Given this list of marker genes APOBR, OGFRL1, NEXN, DYSF, ATP6V1A, DUSP3, FCGR2C, ADA2, MAN2B1, TM9SF2, ASAH1, ADAMTSL4, RHOQ, FMNL2, GSTP1, IGSF6, SCPEP1 (NCBI Gene Id 59342), RAB24, B3GNT5, BMP2K, SPARC, CEBPA, TDRD9, TMEM121B, RNF13, RP2, STXBP2, KIAA0513, PDLIM1, FPR2, ABHD5, MYD88, IGKV1D-13, NCEH1, TET3, ZFHX3, PLXNC1, CD9, MLC1, PTAFR, SMIM14, LILRB3, ARHGAP27, APLP2, GRINA, DGKG, AOAH, RHBDF2, GALNT2, PLXND1, SH2B2, SLC37A2, HLA-DOA, RASGRP4, SH3BP2, RAB3D, REPS2, DPYSL2, TLR4, RB1, ALOX12, LILRA6, PLXNB2, RNASE2 (ribonuclease A family member 2), CLIP2, METRNL, IGKC, ZNF710, CATSPER1, MTMR11, PICALM, CFP, CFD, ZNF385A, STARD3NL, SLC15A3, NADK, RTN1, OSBPL5 (NCBI Gene Id 57656), CYRIB (CYFIP related Rac1 interactor B), VNN2, FEZ2, CEBPB, TLR6, PDGFC, MEIS1 (Meis homeobox 1), OLIG1 (oligodendrocyte transcription factor 1), HDAC9, UNC93B1, OSCAR, SLC7A7, RUBCNL, TM6SF1, WDR11, CD163, PTPRE, SRGN, CES1, MCTP1, CTSZ, ATP6V0A1, SECTM1, RNASE6, IFNGR2, PRKCD, CPNE5, MACROH2A1, XK, RAB32, ITPRIPL2, GSE1, EPB41L3, LAPTM4A (NCBI Gene Id 9741), GBGT1, ASAP2, PTGS1, FCGRT, PLEK, TOR4A, SUSD1, NUDT16, SPOCK1, DGAT2, FBP1, F13A1, TKT, PRCP, CARD9, GLA, DUSP6, PAX5 (NCBI Gene Id 5079), ADGRE2, IGHD, SNAP23, B4GALT6, SIRPB1, PRKAR2B, TTYH3, SYT17, CYFIP1, MXD1, TFEB, SNX2, SLC31A2, FBXL5, TMEM154, LINC00968, SESTD1 (NCBI Gene Id 91404), TMEM170B, SIDT2, CD160, JAK2, EFHD2, ACSL1 (NCBI Gene Id 91249), DRAM1, SORT1, CPA3, SYNGR1, HVCN1, PIP5K1B, ANXA4, CXXC5, FBN2, CPPED1, SETBP1, CCDC88A, RXRA, WDFY4, ZDHHC7, RNF144B, TNFSF13, SEMA4A (semaphorin 4A), LGALS2, IGKV4-1, PCTP, BACH1, MYCL, LTA4H, CD19, SLC22A15, JUP, TRPM2, OAF, ZNF185, SPI1, CD180, PLOD1, TBC1D8, ARSB, NAGK, CMKLR1, TNFSF15, OS9, KCNMB1 (NCBI Gene Id 3779), GFOD1, here is a description of the gene set: from publication Abbas AR, Wolslegel K, Seshasayee D, Modrusan Z, Clark HF (PMID 19568420) studied in species Homo sapiens Human Gene Set: GSE11057_CD4_CENT_MEM_VS_PBMC_DN Genes down-regulated in comparison of central memory T cells versus peripheral blood mononuclear cells (PBMC). Microarray deconvolution is a technique for quantifying the relative abundance of constituent cells in a mixture based on that mixture's microarray signature and the signatures of the purified constituents. It has been applied to yeast and other systems but not to blood samples. Here we test the ability of this technique to determine the fractions of subsets of memory T cells in peripheral blood mononuclear cell (PBMC) samples.